The following is a description of a gene set: studied in species Homo sapiens The amino acid glycine (Gly) plays an important role in neurotransmission. Its action is terminated by rapid re-uptake into the pre-synaptic terminal or surrounding glial cells. This re-uptake is mediated by the sodium- and chloride-dependent glycine transporters 1 and 2 (GLYT1 and GLYT2 respectively) (Broer & Gether 2012, Schweikhard & Ziegler 2012). GLYT2 is encoded by the human gene SLC6A5 and is predominantly expressed in the medulla. Defects in SLC6A5 cause startle disease (STHE or hyperekplexia (HKPX3; MIM:614618)), a neurologic disorder characterised by neonatal hypertonia, an exaggerated startle response to tactile or acoustic stimuli, and life-threatening neonatal apnea. Sometimes symptoms resolve in the first year of life (Bode & Lynch 2014, James et al. 2012). Reactome Pathway: Defective SLC6A5 causes hyperekplexia 3 (HKPX3) part of: SLC transporter disorders, and this is the list of marker genes: SLC6A5